The following is a description of a gene set: species: Homo sapiens from publication Aizarani N, Saviano A, Sagar, Mailly L, Durand S, Herman JS, Pessaux P, Baumert TF, Grün D (PMID 31292543) Human Gene Set: AIZARANI_LIVER_C4_EPCAM_POS_BILE_DUCT_CELLS_1, and this is the list of marker genes: CXADR, NEDD4L, WEE1, CLMN, CTSH, FAIM, RBPMS, SOX6 (NCBI Gene Id 84363), CDH1, AKR1C1, RAP1GAP, DEFB1, CDC42EP1 (NCBI Gene Id 129136), CLDN3, CRYZ, AQP1, ABCC3, SERPINA4, CLDN1, CYP3A7-CYP3A51P, AMOTL2, FXYD2, KCNJ16, TST, MAOA, CHST4, SFRP5, CHST9, CRYAB, COBL, GLIS3, TRNP1, C3, CD24, PRRG4, HABP2, ANXA5, SH3YL1, IRF2BP2, KLF10, CXCL6, ARRDC2, GTF2I, CCN1, CALM2, ITIH2, ELF3, TMEM97, CITED4, S100A14, CKB, FGFR2, ITGB8, TP53INP1, MYRF, NFIB, PLPP2 (NCBI Gene Id 8612), WWTR1, DHCR24, GC (NCBI Gene Id 2638), ANXA4, LAMC1, EGR1, SLC5A1, SHANK2, ANXA13, PROSER2, ANPEP, BACE2 (NCBI Gene Id 25825), ALDH3A2, ALKAL2, PMEPA1, VCAN, CDKN1C, ATF3 (activating transcription factor 3), HNMT, PTPRF, SDC4, SORBS2, DCDC2, C1orf198, HSP90AB1, MGLL, CAMK2N1, CA2, SYNJ2, KRT18, APOB, CTDSPL, RAB3IP, PERP, SPINT1, MUC6, NFIC, KRT8, SPINT2, KIF12, SDC1 (NCBI Gene Id 6382), PHGDH, MYO10, ITGB5, CLIC6, CPB2 (carboxypeptidase B2), BICC1, SPATS2L, FMO5, SERPINA6, PLXNB1, HSD17B2, KRT7, ALCAM, CLU, SLC4A4, ATP1B1, SERPINA5, PALS2, MAGI1, RHOB, CAV2, HOMER2 (NCBI Gene Id 9455), SNRPN, VTN, AKR1C2, KANK2 (KN motif and ankyrin repeat domains 2), PROX1, SCARB2, FGFR3, ZBTB20, SOX4, HSD17B11, GDF15 (NCBI Gene Id 9518), PTPRK, PAQR5 (progestin and adipoQ receptor family member 5), LAMP2, PKHD1, MYLK, CPM, TACSTD2, LAD1, FAM171A1 (family with sequence similarity 171 member A1), ATP1A1, LGALS4, TOB2, CLDN10, HES1, SLC37A4, CCN2, SHROOM3, CPD, COL27A1, BEX3, CDH2, PWWP3B, OCLN, EPCAM, DSTN, AMBP, SPP1, NHSL3, CLDN4, AFDN, TMEM245, GOLM1, TM7SF3, DSP, BAMBI, CLDN7, TESC, TM4SF4, ERICH5, EMP2, CCDC198, PAWR, SLPI, GLUL, PAH, ERRFI1, TMPRSS2, TNFRSF12A, VEGFA, CD59, CYP3A5, MARVELD3, ENPP2, SOX9, SLC12A2, SOD3, AGT, ERBB3, NR2F2, SLC17A4